Given this list of marker genes POLR2K, CCNH, POLR2A, GTF2H4, TAF7, POLR2J, ILK, TAF13, MNAT1, POLR2G, GTF2A2, ERCC2, POLR3H (NCBI Gene Id 91605), POLR2B, POLR3E, POLR3B, POLR2I, POLR2F, CDK7, GTF2H2C, POLR1B, TAF12, GTF2H3, GTF2E1 (general transcription factor IIE subunit 1), POLR1A (NCBI Gene Id 90784), POLR2C, TAF5, ERCC3, POLR3D, TBP, POLR1E, TAF6, POLR3K, POLR2H, GTF2H1, GTF2H2, POLR2E (RNA polymerase II, I and III subunit E), POLR1D, GTF2B, GTF2E2, GTF2F2, TAF9, here is a description of the gene set: Human Gene Set: WP_EUKARYOTIC_TRANSCRIPTION_INITIATION Eukaryotic transcription initiation species: Homo sapiens